Given this list of marker genes VPS33A, VPS41, AKTIP, VPS39, HOOK1, VIPAS39, HOOK3, VPS8, STX17, VPS18 (NCBI Gene Id 57617), HOOK2, VPS33B, VPS11, VPS16, here is a description of the gene set: species: Homo sapiens A multimeric protein complex that associates with the vacuolar membrane, late endosomal (multivesicular body) and lysosomal membranes. HOPS is a tethering complex involved in vesicle fusion. Human Gene Set: GOCC_HOPS_COMPLEX